The following is a description of a gene set: Catalysis of the reaction: 5-alpha-androstane-3-beta,17-beta-diol + NADP+ = 17-beta-hydroxy-5-alpha-androstan-3-one + H+ + NADPH. Human Gene Set: GOMF_5_ALPHA_ANDROSTANE_3_BETA_17_BETA_DIOL_DEHYDROGENASE_NADPPLUS_ACTIVITY studied in species Homo sapiens, and this is the list of marker genes: AKR1C1, HSD17B6, HSD17B7, HSD3B1, AKR1C4, AKR1C3